The following is a description of a gene set: Binding to and carrying a protein between two different cellular components by moving along with the target protein. studied in species Homo sapiens Human Gene Set: GOMF_PROTEIN_CARRIER_CHAPERONE, and this is the list of marker genes: EMC8, EMC4, NAP1L1, ASF1A, MMGT1, HSPA8, EMC2, MYD88, MTCH1, OXA1L, TIMM10, VPS72, GET3, APLF, PEX5, ANKRD13C, CLU, PRDM12, EMC6, BAG6, IPO9, GET4, ANP32E, MTCH2, EMC10, ASF1B, HIRIP3, COX18, BAG3, JDP2, EMC7, SPTY2D1, WRAP53 (WD repeat containing antisense to TP53), EMC3, PWP1, WFS1, DUSP16, PTMA, EMC1, TIMM9, PEX19 (NCBI Gene Id 7835), EMC9 (ER membrane protein complex subunit 9)